Given this list of marker genes ATR, H2BC8, PSMB3, MCM7, RFC4, DNA2, H4C15, H2BC11, PSMA3, CDC25A, ORC1, ADRM1, EXO1, CCNA1, ORC2, ORC3, CDC6, PSMA7, RAD17, HERC2, PSMB5, PSMD11, H4C14, GTSE1, BABAM1, H2BC6, CDC7, H2BC15, TP53BP1, RBBP8, BLM, H2BC21, CCNB2, PSMA5, H2BC10, WRN, PSMB2, PSMB4, RPA1, H4C5 (H4 clustered histone 5), RAD9B, RHNO1, CDK1, PSMD12, H2BC17, ORC6, PSMA4, H2BC3, H4C12, RAD50, H4C2, ATRIP, MCM8, RMI2, PSMA1, CHEK2, H2BC12L, H4C9, BRCA1, PSMC1, NSD2, DBF4, HUS1, H4C4, PSMC5, RAD9A, YWHAZ, H2BC4, PSMD8, PKMYT1, KAT5, CHEK1, MCM2, H4C6, H4C13, PSMA6 (proteasome 20S subunit alpha 6), H2BC1, SFN, CDK2, RFC2, MCM6 (NCBI Gene Id 4175), CCNB1, H4C16, TOP3A, H2BC5 (H2B clustered histone 5), PSMD7, YWHAB, PSMB6, UBC, MCM10, PSMB1, PSMD1, CCNA2, H4C8, H2BC9, MDC1 (NCBI Gene Id 9656), H4C11, RNF168, ORC4, MCM4, PSMC6, RMI1, YWHAH, RFC5, WEE1, RPA2, ABRAXAS1, PSMD13, PSMD6, TOPBP1, SEM1, PSMD14, PSMC3, PSMA2, ORC5, H2BC12, MCM3 (minichromosome maintenance complex component 3), H2BC7, H2BC13, UBE2V2, H3-4, MRE11, CDC25C, RNF8, CDC45, CLSPN, UBE2N, MCM5, PSMD3, UIMC1, UBA52, H4C3, YWHAE (NCBI Gene Id 7531), H2BC14, YWHAQ, TP53, BABAM2, PSMD2, PSMC4, H2AX, YWHAG, PSMC2, ATM, NBN, RFC3, RPS27A, PIAS4, PSMB7, RPA3, RAD1, BRCC3, H2BC26, BRIP1, UBB, H4C1, BARD1, here is a description of the gene set: Human Gene Set: REACTOME_G2_M_CHECKPOINTS G2/M Checkpoints species: Homo sapiens